Given this list of marker genes Hrg, F2, Camp, Apol11a, Ltf, Romo1, Spag11b, here is a description of the gene set: species: Mus musculus The killing by an organism of a cell in its symbiont organism by means of the rupture of cell membranes and the loss of cytoplasm. The symbiont is defined as the smaller of the organisms involved in a symbiotic interaction. Mouse Gene Set: GOBP_CYTOLYSIS_BY_HOST_OF_SYMBIONT_CELLS